The following is a description of a gene set: Generation of a long process of a pyramidal cell, that carries efferent (outgoing) action potentials from the cell body in cerebral cortex layer V towards target cells in the gray matter of the spinal cord. This axonal process is a member of those that make up the corticospinal tract. studied in species Homo sapiens Human Gene Set: GOBP_CORTICOSPINAL_TRACT_MORPHOGENESIS, and this is the list of marker genes: SLIT2, EPHA4, FBXO45, NIN, CDH11, SCN1B, PRDM8, ZEB2, SPG11 (SPG11 vesicle trafficking associated, spatacsin)